Given this list of marker genes KIAA1217, CFAP263, PPIL2 (peptidylprolyl isomerase like 2), ADARB2, BBS2, POM121L2, GJA1, OPN1LW, IL9, EYA3, CRYBA4, ADORA1, ADGRA1, KPNB1, FANCA, GFAP, ODAD3, STN1, TGM1, DEGS1, KRT18, SLC25A35, PAWR, CBFB, SEMA6D, NT5C3B, ARHGAP24, OTUB1, NAT2, SPAG4, RCBTB1, PCOLCE, FMNL2, SLC66A2, TJP1, MINAR1, KIAA0040, SPPL2B, DHRS13, GNA14, GLP1R, GALNT18, KANK4, TIGAR, AGPAT1, EIF4ENIF1, MRM1, PLA2G12B, TUBGCP2, GPR85, SCUBE3, PTPRM, C1orf56, POU2F3, SPATA18, SLC39A14, CREG2, RTL5, PLXNA1, TSSK1B, SOX14, ZFP57, RSPO1, EPB41, CYSLTR2, IFI44L, GJB1, ARHGAP39, PHF19, FPR3, IRAK3, ZIK1, TBL1X, CCNYL1, SLIT3, USHBP1, CLPS, TCTE1, SYPL2, SCAMP5, TCP10L, DIRAS1, SNX7, KLKB1, ZKSCAN4, ZHX2, AMELX, STMN2, AVP (NCBI Gene Id 551), SLC12A3, ENPP2, PKD2L2, GPR19, HP1BP3, KBTBD12, NPVF, SSTR4, NLRP9, ROR2, SMTNL2, SOWAHB, CSTPP1, KTI12, INSYN1, OCEL1, PTCD2, DRAXIN, TMEM108, C19orf33, LMNTD1, SERTM1, KRT6A, OPA3, NDUFV1, NOS1AP, SLC16A10, LRRC17, PRCP, ANKRD12, PRSS23, MIEF2, SERPINA10, POLD1, CYP2S1, MYO1G, TRIM42, RGS6, POC1A, SLC35F1, DOK4, AGO2, CLDN16, GIPR, GCKR, SFI1, FKBP10, CYP39A1, SLC4A9, UROD, MYBPC2, SRP72, MIOX, ZNF428, CSPG5, PRR15, SNTA1, CDC34, TSEN34, ADARB1, ANKRD31, PCDHA11, DRD4, SMARCC2, PEMT, DYNLT5, MCOLN2, STRA8, RAB42, ATG7, YKT6, ZW10, NTN1, ASPH, NCOA7 (NCBI Gene Id 135112), ABCG4, AQP7, SPMAP2L, ALG8, CRYGD (crystallin gamma D), EXTL3, PKN1, NRP2, RMI2, RNF181, OGG1, NBEAL2, VIT, C16orf78, CLDN22, GJC2, CRYAA, FLNA, HAX1, GPX5, FMR1, RILP, SUPV3L1, PRSS27, BHLHA15, KCNH5, CC2D2A, CIART, HSPB9, MYLK2, ACOX3, PDE3A, TLE6, HOXA11-AS, C3orf38, here is a description of the gene set: The transcription factor Foxp3 is usually considered the master regulator for the CD4+CD25+ Human Gene Set: GSE7460_CTRL_VS_FOXP3_OVEREXPR_TCONV_UP Genes up-regulated in comparison of Ctrlrv versus Foxp3rv (see Fig. 1 in the paper for details). from publication Hill JA, Feuerer M, Tash K, Haxhinasto S, Perez J, Melamed R, Mathis D, Benoist C (PMID 18024188) species: Homo sapiens